The following is a description of a gene set: Any process that activates or increases the frequency, rate or extent of protein targeting to mitochondrion. studied in species Mus musculus Mouse Gene Set: GOBP_POSITIVE_REGULATION_OF_PROTEIN_TARGETING_TO_MITOCHONDRION, and this is the list of marker genes: Ptpn5, Hspa1l, Adcy10, Tomm7, Tomm70a, Pdcd5, Fbxw7, Pdcd5-ps, Prkaa1, Gsk3a